The following is a description of a gene set: A process carried out by gene products in an organism that enable the organism to engage in a symbiotic relationship, a more or less intimate association, with another organism. The various forms of symbiosis include parasitism, in which the association is disadvantageous or destructive to one of the organisms; mutualism, in which the association is advantageous, or often necessary to one or both and not harmful to either; and commensalism, in which one member of the association benefits while the other is not affected. However, mutualism, parasitism, and commensalism are often not discrete categories of interactions and should rather be perceived as a continuum of interaction ranging from parasitism to mutualism. In fact, the direction of a symbiotic interaction can change during the lifetime of the symbionts due to developmental changes as well as changes in the biotic/abiotic environment in which the interaction occurs. Microscopic symbionts are often referred to as endosymbionts. Human Gene Set: GOBP_BIOLOGICAL_PROCESS_INVOLVED_IN_SYMBIOTIC_INTERACTION species: Homo sapiens, and this is the list of marker genes: CTSG (cathepsin G), AGTR1 (NCBI Gene Id 9449), CR1, SMPD1, HTR2A, DDB1, ICAM1, KIAA0319L, SELPLG, EXOC7, CD209, DAO, LAMP3, TSG101, AXL, MOG (myelin oligodendrocyte glycoprotein), INHBB, EFNB2, FMR1, PF4, WWP2, ITGB1, LRRC15, ITGB7, P4HB, DAG1, CR2, WWP1, KRT6A, CDHR3, CLEC5A, NUP153, CH25H, ITGA5, HLA-DRB1, CFHR2, ITGAV, DEFB130A, FN1, SCNN1B, PGLYRP3, AZU1, NECTIN3, LGALS1, DEFA5, PCYOX1L (NCBI Gene Id 78991), HAVCR1, ITGB6, CFHR1, ROMO1 (reactive oxygen species modulator 1), SCARB1, CD80, PGLYRP2, NRP1, TPCN2, IDE, MIR130A, HSPA1A, CLEC4G, CCR5, CD4, EXOC2, DPP4, HRG, KPNA2, GRK2, NCAM1, F2RL1, EFNB3, MYD88 (NCBI Gene Id 4615), FUCA2, ARG1, LDLR, BPIFA1, CFHR5 (NCBI Gene Id 81494), ILF3, IFIT1, VPS18, TRIM11, BSG, CDK1, UVRAG, MIR30C1, HYAL2, SRC, SLC1A5, TFRC, CLEC4M, JPT2, PPARA, SCARB2, FURIN, SLC10A1, CHMP6, PVR, CAMP, CYSRT1, HSPA1B, GYPA, TREM1, VAPB, PPID, TNFRSF4, VPS37B, FBLN1, MIR141 (microRNA 141), TRIM5, NPC1, TYRO3, CTSB, NECTIN4, CHMP4A, CLDN6, GSDMB, SERPINB3, F11R, HSPD1, XPR1, HS3ST5, ACE2, CXADR, APOL1, CBL, AVPR1B, LAMP1, NECTIN1, NECTIN2, ITGB5, CD74, VAPA, NLRP6, SLC52A2, CHMP5, SLC52A1, CXCL6, GPX1, MYH10, CD81, ITGB3, SPAG11B, CD86, TMPRSS4, CHMP1B, MRC1, TRIM62, ELANE, CD55, EPS15, SLAMF1, DEFB103B, HSP90AB1, ITCH, PC, MYH9, SLC3A2, CHMP2B (NCBI Gene Id 7877), CAV1, KPNA3, ITGA2, PHB1, NCF1, VPS4B, VAMP8, DEFA1, NMT2, CHMP7, CLDN9, CHMP2A, KPNA6, RPSA, TRIM15, PLG, SLC20A2, GAS6, RAB7A, CXCR4, GAPDH, ANPEP, GPR15, LGALS9, AVP, CHMP1A, F2, TRIM25, CHMP4B, LTF, TMPRSS2, CD46, EGFR, CTSL, PLSCR1, SLC7A1, TPCN1, DYNLT1, TRIM21, EPHA2, PGLYRP1, PIKFYVE, TRIM31, CXCL8, RNASEK, TNFRSF14, PPIA, CHMP3, POMC, SIVA1, SIGLEC1, CHMP4C, CLDN1, DEFB103A, ARL8B, CHMP4BP1, CAV2, ZNF639, DEFA1B, HMGB1 (NCBI Gene Id 3146), INSR, MBL2, TRIM38, BST2, DCD, ZNF502, TUSC2, VPS4A